Given this list of marker genes Lif, Stx2, Mst1, Mirlet7d, Il11ra1, Acod1, Ggn, Mir26a-1, Itgb4, Cdh1, Nlrp5, Lamb1, Sod1, Mirlet7c-2, Mug1, Fbn2, Aplf, Zscan4b, Arhgdib, Mirlet7a-2, Syde1, Fut7, Mir26a-2, Arid1a, Bsg, Vegfa, Mmp9, Trim28, Ptgis, Smad3, Rxra, Nodal, Ddr1 (NCBI Gene Id 268950), Mirlet7a-1, Smurf2, Acvr1b, Mirlet7b, H3f3b (NCBI Gene Id 78941), C1qbp, Mirlet7c-1, Grn, Polr1b, Acvr1c, Itgb3, Stc1, Prss29, Epo, Ythdf3, Apela, Ptgs2, Prss28, Errfi1, Atr, Mir143, Ube2q1, Hmx3, Fbln1, A1cf, Gja1, Calr, Zscan4a, Ints1, Emp2, Ubtfl1, Reck, Tgfbr1, Tppp3, Pcsk5, Il11ra2, Il11ra3, Stc2, Fkbp4, Mir20a, H2-Q7, Prdm14, Klf9, Mmp12, Timp1 (tissue inhibitor of metalloproteinase 1), Mmp2, Ooep, Tead4, Vmp1, Exoc1, Smad2, Ppard, Pzp, Ago2, here is a description of the gene set: Mouse Gene Set: GOBP_EMBRYO_IMPLANTATION Attachment of the blastocyst to the uterine lining. species: Mus musculus